Given this list of marker genes Trim56, Rbck1, Hamp, Rnf25, Fbxw7, Trim65, Anapc2, Tmem129, Ube2l3, Peli3, Ube2d2a, Ube2dnl2, Ube2n, Anapc4, Itch, Anapc11, Trip12 (thyroid hormone receptor interactor 12), Trim62, Wdr77, Ube4a, Dcaf15, Trim12a, Ube2h, Ube3c, Mgrn1, Dysf, Huwe1 (HECT, UBA and WWE domain containing 1), Trim30d, Fbxo22, Rnf216, Cdc26, Skp2, Ube2l6, Pex10, Ube2t, Aktip (NCBI Gene Id 14339), Cbl, Rnf14 (ring finger protein 14), Trim25, Fbxo45, Tnks, Pex12, Cdc16, Ercc8, Bcl2, Lrsam1, Pnkp (NCBI Gene Id 76351), Kbtbd6, Birc3, Trim12c, Trim30c, Gabarap, Wsb1, Bard1, Ube2c, Ube2r2, Ube2ql1, Nt5c2, Dtl, Toporsl, Nhlrc1 (NHL repeat containing 1), Ube2v2, Tnks2, Xiap, Klhl42, Cul1, Klhl20, Trim38, Dda1, Trim32, Brca1, Cdkn2a, Dzip3, Rnf6, Fbxo28, Ube2dnl1, Ube2w, Zswim2, Nfe2l1, D7Ertd443e, Daw1, Sash1, Znrf1, Ube2k, Arih2, Rnf34, Nedd4, Rnf187, Ube2q2l, Wwp2, Tcf25, Ube2j2, Gps2, Ube2q2, Tradd, Peli2, Nqo1, Cbfb, Mkrn1, Bfar, Anapc13, Ube2a, Anapc15-ps, Cdc27, Cdc34, Kcmf1, Trim71, Spsb3, Parp10, Rnf8, Ube2u, Ttc3, Ube2b (NCBI Gene Id 67159), Axin1, Ubox5, Marchf5 (NCBI Gene Id 78729), Sharpin, Rnf20, Ubr4, Ube2d2b, Marchf6, Rc3h2, Rnf115, Ddb2, Rnf5, Rnf4, Rffl, Ube2e3, Rc3h1, Arel1, Nod2, Rnf114, Topors, Cdc23, Rmnd5a, Dtx3l, Tnfrsf1a, Trim3, Ripk2, Mycbp2 (NCBI Gene Id 97940), Spop, Rnf183, Rbx1-ps, Irf2bp1, Rnf26rt, Trim5, Rnf185, Rbx1, Ube2d1, Ppil2, Rnf213, Kbtbd7, Foxf2, Trim6 (NCBI Gene Id 94088), Traf7 (TNF receptor-associated factor 7), Fbxl17, Nmi, Trim45, Rnf167, Stub1, Hdac6, Rnf166 (ring finger protein 166), Ube4b, Cul4b, Plaa, Chfr, Smurf1, Fbxo4 (NCBI Gene Id 67521), Rnf186, Znrf2, Tnfaip3, Anapc1, Magel2, Ube2g1, Trim31, D1Pas1, Rnf126, Fbxo38, Fbxw11, Rnf123, Jade2, Trim58, Ddx3x, Mkrn3, Hamp2, Skp1, Mkrn2, Zfp598, Trim27, Rnf125 (ring finger protein 125), Anapc5, Anapc15, Asb17, Ptpn22, Peli1 (pellino 1), Spsb4, Asb11, Trim44, Rnf111, Map3k1, Ube2g2 (NCBI Gene Id 68471), Wdr24, Cep63, Prkn, Marchf8, Cdc34b, Prpf19, Ube3a, Traf6, Rnf168, Ube2e1, Ark2c, Rnf40, Trim55 (tripartite motif-containing 55), Rnf26, Ube2e2, Rnf152, Hace1, Fbxo7, Ube3d, Trim26 (tripartite motif-containing 26), Marchf1, Anapc16, Kbtbd2, Btrc, Rnf144a, Ubr5, Klhl3, Trim30b, Dtx4, Zfp91, Anapc10, Tnf, Birc2, Amfr, Rnf135, Arrdc4, Ube2v1 (NCBI Gene Id 66589), Ppia, Fbxl7 (F-box and leucine-rich repeat protein 7), Hectd1, Nhlrc3, Wsb2, Ubr2, Nedd4l, Rnf31, Ube2srt, Trim30a (tripartite motif-containing 30A), Marchf7, Ttc36, Fbxo9, Ctnnb1, Shprh, Ube2s, Mul1, Rusc1, Ube2d3, Anapc7, Ube2j1, Trim2, Cul3, Traf2, Ube2o, Rnf170, Ambra1, Rnf180, G2e3, Ube3b, Traf3ip2, Trim21, Rnf146, Trim8, Syvn1, Rnf41, Hectd2, Ube2q1, here is a description of the gene set: species: Mus musculus Addition of multiple ubiquitin groups to a protein, forming a ubiquitin chain. Mouse Gene Set: GOBP_PROTEIN_POLYUBIQUITINATION